The following is a description of a gene set: Human Gene Set: CACTGTG_MIR128A_MIR128B Genes having at least one occurence of the motif CACTGTG in their 3' untranslated region. The motif represents putative target (that is, seed match) of human mature miRNAs hsa-miR-128a and hsa-miR-128b (v7.1 miRBase). species: Homo sapiens, and this is the list of marker genes: LSM1, PPME1, NCAN, ACOT11, SPATA2, BMI1 (BMI1 proto-oncogene, polycomb ring finger), KLF4, PELI3, UBE2E3, CORO1C, INSM1, WEE1, XPR1, GPAM, ARRDC4, ADCY2, BCL11A, TGFBR1, TBC1D9B, NALF2, MIER2, IRS1, DAZAP2, ARMC8, AMER2, TBC1D22B (NCBI Gene Id 55633), TMEM266, RSBN1, MNT, ERC2, COL3A1, CDH24, PPP1CC, NEUROD1, RPS6KA5, ARID4B, PLAGL2, ZNF652, IKZF4, ADCY3, RERE, ORC5, FADS1, PDPK1, DCUN1D4, UBR1, SMG1, IPO7, NGFR, APBA2, NEO1 (NCBI Gene Id 4756), SETD7, ARK2N, PRKX, RGS6, BAZ2B, PHF6, PTPN4, DCP2, CABLES2, SH3RF1, OTULIN, RUNDC3A, RAP1B, PDIA5, IGSF3, DVL2, MGAT1, STIM2, H3-3B, MAPK6, ITGA5, AMMECR1L, ISL1, CANX, KCNAB1, UBE2NL, RND3, NHS, MDFI, DCUN1D1, MPPED2, ZNF24, VANGL1, RLIM, SS18, PDHX, ARHGEF6, NREP (NCBI Gene Id 9315), RETREG3, ZKSCAN2, ARL8B, PDE7B, UNC5D, SEMA6D, TFEB, PITPNM2, CCDC6, ATXN10, CD34, FAR1, MCRIP2, CCDC92, MTDH, RNF144A (ring finger protein 144A), CTDSP2, MEGF11, RNGTT, SPTY2D1, BTG2, FAAP100, RGL2, FBXO33, GTF2A2, SHOC2, SPOPL, NHLH2, PTPN9, NAB1, TMX1, MED13L, ULK1, MAP2K7, ZNF385A, MME, ZFP36L1, ENAH, ARPP21, MIR1915HG, SH2D3C (NCBI Gene Id 10044), VANGL2, HYCC1, INTS11, UBE2E2, PIK3R1, KMT2A, FURIN, GAD1, RORB, SEC61A1, BAHD1, FAM177A1, LRR1, ZKSCAN8, MIEF1, SRGAP2, CASC3, AFF4, PHAF1, CDIP1, NEUROD6, SAMTOR, ARHGAP12, SOCS6, SLC6A1, FRMD4A, TMEM132E, HIP1, TSTD2, NEK2, FOXN3, FOXQ1, LETMD1, MTMR4, POGLUT1, CNOT6, RYBP, MAP4K5, SLC39A13, EIF2S2, DIRAS2, CA7, YPEL3, CABP1, PPP4C (NCBI Gene Id 5531), GABBR2 (NCBI Gene Id 9568), ZNF827, SP2, LRATD2, CHRD, RASGEF1B, CPD, ARHGAP21, RELN, CA12, PLK2, MAPK8IP3, ITPKC, SYT1, CITED2, BCORL1, NAA15, PTER, LMBR1L, GCC1, MOSPD3, DCP1A, PFKM, RPS6KB1, CBX5, HAO1, SYNDIG1, ARHGEF11, NPTX1, STRN4 (NCBI Gene Id 29888), CA10, CCDC71, CCDC88A, EVI5, CDC14B, HMGB3, FBLN2, GAD2, NPTX2, DPY19L3, ELOVL6, TMEFF1 (NCBI Gene Id 8577), ARID1A, RNF38, AK2, HYCC2, GLTP, DCX, GATAD2A, WDTC1, CEMIP, SIRT1, C11orf87, NIPBL, PDE3A, PRKD1, F13A1, TRIL, KLHDC8A, KAT7, CLSTN2, NDST1, MXI1 (MAX interactor 1, dimerization protein), CRKL, ELOVL4, TMTC2, SYT4, FOXO4, PTPRT, SASH1, CSF1 (colony stimulating factor 1), SPTBN4, UBE2W, TAF4, TMEM25, SP4, ARID1B, NAA50, UPF1, VPS4B, LIN28A, STK35, LBH, PPP1R11, LTBP1, FAM184A, CTDSPL, AGPAT4, E2F3, YWHAB, TCF20, PRKY, SV2A, ZBTB39, UBE2Z, CNR1, MGAT4B, MAPK14, SZRD1, DCAF7, NXT2, PAIP2, SMARCA2, KCNK10, PTGR3, PPM1E, ACVR2A, MED13, TENT4A, PHB1, TNPO3, TMSB10, STK24, WASHC4, C1orf21, DTX1, CCT3, RAB11FIP1, GNB2, H3-5, FAM78A, ELMO1, SP1, SLC25A3, EPHB2, HECTD1, SH3BGRL2, LMTK2, ABCB9, MIPOL1, BAG2, UBE2N, FXR2, LHFPL3, DMTN, PTPN5, STK40, ABHD17B (abhydrolase domain containing 17B, depalmitoylase), CTDSPL2, NAV3, KIAA0232, DERPC, ZC3H12B, PGAP1, SGMS1, HOXA13, AMD1, AXIN1 (NCBI Gene Id 8312), DIRAS1, STEAP3, MPP2, SREK1, WTAP, RIMS3, SAMD10, WNT3A, SEPTIN3, SET, NTRK3, NRBF2, UBR5, DDX6, CXCL2, EFR3A, HAS3